The following is a description of a gene set: part of: Mucopolysaccharidoses studied in species Homo sapiens Reactome Pathway: MPS IX - Natowicz syndrome (Hyaluronan metabolism) Mucopolysaccharidosis type IX (MPS IX, Natowicz syndrome, Hyaluronidase deficiency, MIM:601492) is a rare lysosomal storage disease characterized by high hyaluronan (HA) concentration in the serum resulting from deficiency in hyaluronidase 1 (HYAL1, MIM:607071) which normally hydrolyses 1-4 linkages between N-acetylglucosamine (GlcNAc) and D-glucuronate (GlcA) residues. Symptoms of MPS IX are periodically painful soft tissue masses around the joints, acquired short stature and erosion of the hip joint, although joint movement and intelligence are normal., and this is the list of marker genes: HYAL1